Given this list of marker genes Sycp2, Paupar, Chek2, Cdc20, Nfe2l1, here is a description of the gene set: One of the distinct periods or stages into which the mitotic cell cycle is divided. Each phase is characterized by the occurrence of specific biochemical and morphological events. Mouse Gene Set: GOBP_MITOTIC_CELL_CYCLE_PHASE studied in species Mus musculus